Given this list of marker genes Ybx1, Dhx9, Csde1, Syncrip, Igf2bp1, Hnrnpu, here is a description of the gene set: studied in species Mus musculus A protein complex that binds to, and promotes stabilization of, mRNA molecules containing the coding region instability determinant (CRD). In human, it may consist of IGF2BP1, HNRNPU, SYNCRIP/HNRNPQ, YBX1, and DHX9. Mouse Gene Set: GOCC_CRD_MEDIATED_MRNA_STABILITY_COMPLEX